The following is a description of a gene set: Human Gene Set: GAVISH_3CA_METAPROGRAM_CD8_T_CELLS_HEAT_SHOCK In this study, an extensive analysis was conducted to define meta-programs (MPs) capturing intra-tumor heterogeneity across a spectrum of tumor types. The approach utilized non-negative matrix factorization (NMF) to analyze each cell type separately within individual tumor samples. This involved the analysis of malignant cells, macrophages, fibroblasts, endothelial cells, epithelial cells, T-cells, and B-cells. NMF was executed with varying parameter values (K=4, 5, 6, 7, 8, 9), thereby generating 39 programs for each cell type per sample. Each NMF program was summarized by the top genes based on NMF coefficients.\nRobust MPs were then delineated for each cell type using a set of stringent criteria, including recurrence within the same tumor, similarity to programs in other tumors, and non-redundancy within a tumor. Subsequently, these robust NMF programs were clustered (per cell type) based on Jaccard similarity, leading to the identification of MPs associated with each cell type.\nTo enhance the quality of the MPs, a refinement steps were undertaken, involving the removal of MPs suspected of reflecting low-quality data (with an overrepresentation of ribosomal proteins or mitochondrial-encoded genes), single-study inclusion, or similarity to miss-annotated cell types. from publication Gavish A, Tyler M, Greenwald AC, Hoefflin R, Simkin D, Tschernichovsky R, Galili Darnell N, Somech E, Barbolin C, Antman T, Kovarsky D, Barrett T, Gonzalez Castro LN, Halder D, Chanoch-Myers R, Laffy J, Mints M, Wider A, Tal R, Spitzer A, Hara T, Raitses-Gurevich M, Stossel C, Golan T, Tirosh A, Suvà ML, Puram SV, Tirosh I (PMID 37258682) Genes upregulated in subsets of cells of a given type within various tumors species: Homo sapiens, and this is the list of marker genes: DUSP1, CCL3, ANKRD37, TCP1, BAG3, NUDC, HSPD1, NEU1, CACYBP, PTGES3, TAF7, HSPE1, CLK1, CHORDC1, DUSP4, SQSTM1, FKBP4, HSPA6, ZFAND2A, BATF, DOK2, AHSA1, GADD45B, HSPA1B, TXNIP, DNAJB1, HSPA1A, DNAJA4, SERPINH1, MRPL18, JUN, HSPA4, RHOB, PPP1R15A, HSPB1, NR4A2, HSPH1, TSPYL2, CCL4L2, STIP1, NR4A1, PMAIP1, RGS2, TNFSF14, FOSB, IFNG, DEDD2, HSP90AB1, HSP90AA1, DNAJA1